The following is a description of a gene set: Human Gene Set: GSE7460_CD8_TCELL_VS_CD4_TCELL_ACT_UP Genes up-regulated in comparsion of ActCD8 versus ActCD4 (see Fig. 1 in the paper for details). The transcription factor Foxp3 is usually considered the master regulator for the CD4+CD25+ species: Homo sapiens from publication Hill JA, Feuerer M, Tash K, Haxhinasto S, Perez J, Melamed R, Mathis D, Benoist C (PMID 18024188), and this is the list of marker genes: ZNF229, CD38, CTLA4, TNFRSF13C, SESN2, CCR5, ZCCHC18, TNFSF10, S100A4, UBXN2A, OR4C3, ZFP36L1, CCL5, OSTF1, CEP162, KLRK1, INVS, MIR22HG, TENT5B, EML3, ITGAL, DENND4C, SERPINA5, GTF2I, DNAJB6, ADAMTS12, KLRC1, USP30 (NCBI Gene Id 84749), PRRT1, EML2, IKZF2 (NCBI Gene Id 51173), POLR3A, MIGA1, DENND4A, ATP8B4, GPR15 (NCBI Gene Id 2838), DGAT1, TAPBPL, BCORL1, GZMA, MPPE1, GPR160, ABCC9, TRAFD1, NSMAF, YES1, TMED3, TOGARAM1, FAM241A, CXCR3, CRACDL, ABHD15, ATXN1, ICAM1, LGALS3BP, FASLG, PON3, PLEKHM3, CALHM6, RBMS2, CASS4, CAMK2G, EIF2B4, FIRRE, USP24, SLC6A3, LINC01160, CD8A, UCK1, C5orf46, RNPEP, APOOL, CLIC5, POLM, VMP1, HSDL2, HGSNAT, ALS2, SLC13A1, IRF1, CD8B, CXCR5, NCALD, PSME2, PLAUR, DNAJA4, PLCG2, BAIAP3, IFNG, GBP4, IFNGR1, SYT10, USP11, FAM174B, FNBP4, GOLM2, CMTM7, B4GALNT1, PLAC8, HOPX, SEMA4F, FCHSD2, CXCR6, LAX1, NBEAL2, FBXL5, DDHD2, USP42, AGPAT4, HOOK2, NLRC5, PLEK, AK3, PDE7A, CERK, SLC9A5, FOXA1, C1GALT1, NKG7, CHST11, CAMK2N1, F13A1, FRRS1, GGH, SOAT2, TAB2, PHETA2, RNF138, RACK1, SKIL, RUNX2, GFI1, SPIN4, GARIN3, PTPN22, MARCHF5, LGALS3, TTC39C, DDC, FHL2, STOML1, SIDT1, CCDC6, SLC9A9, ACOT9, KCTD12, GBP6, HCK, GZMK, VPS37A, NEUROD4, ZDBF2, FRMD4A, AOPEP, SIRT3, ZNF354A, PRRG2 (NCBI Gene Id 5639), ZBTB26, PIGP, PBX4, LPIN2, ARID3A, STXBP4, MYO1F, RGS3, S100A6 (S100 calcium binding protein A6), RMDN2, RECK, MCTP2, SMPDL3B, NCF1, SLAMF7, SLC25A53, EPSTI1, UNC119B, PLXDC1, DSE, SMIM3, ZNF131, ABTB3, TBX21, ARHGAP26, PREX1, LYN, PTDSS2, LPXN, CST7, RILPL2, FGL2, SH3RF2, ALPL, NOTCH1, CTSW (cathepsin W), TASL, ZNF2, NDNF, IKZF3 (NCBI Gene Id 22806), PARP8, DSG2